The following is a description of a gene set: Scapuloperoneal amyotrophy Muscular atrophy in the distribution of shoulder girdle and peroneal muscles. Human Gene Set: HP_SCAPULOPERONEAL_AMYOTROPHY studied in species Homo sapiens, and this is the list of marker genes: MYH7, LMNA, PLEKHG5, TRPV4, POMT2